The following is a description of a gene set: from publication Szanto A, Balint BL, Nagy ZS, Barta E, Dezso B, Pap A, Szeles L, Poliska S, Oros M, Evans RM, Barak Y, Schwabe J, Nagy L (PMID 21093321) Human Gene Set: GSE16385_IFNG_TNF_VS_UNSTIM_MACROPHAGE_ROSIGLITAZONE_TREATED_UP species: Homo sapiens Genes up-regulated in macrophages (12h): IFNG, TNF and rosiglitazone versus rosiglitazone. Human CD14 positive monocytes were purified from healthy volunteers’ blood and cultured in vitro for 4, 12, 24, 72 hours. While culturing, macrophages were activated alternatively with interleukin-4 (IL-4 100 ng/ml) or classically with interferon-gamma (IFNg 100 ng/ml)+tumor necrosis factor (TNF 50 ng/ml) or left without activation. Simultaneously, macrophages were also treated with vehicle (DMSO:ethanol) or 1mM synthetic PPARg agonist, Rosiglitazone. We used Affymetrix microarrays (U133Plus 2.0) to analyze activation and PPARg-induced gene expression changes., and this is the list of marker genes: SFT2D3, VTI1A, KEL, CARD11, EIF2AK2, EN1, LDLR, TBPL1, MAP7D1, LINC01093, ACAA1, SLC9A1, AIMP1, STAM, LRRN2, KRBA2, SAMD5, IL4I1, CGN, TEX46, BTN3A2, TMEM268, GPN2, PDXDC2P, RELA, GCH1, SUPT4H1, ZNRD2, XKR8, TRNAU1AP, LGALS3BP, PICART1, BCL7B, SDSL (NCBI Gene Id 113675), UBE2Z, ZNF496, KCNQ1OT1, IGHV1-69, MAX, HLA-J, USP11, CXXC1P1, MFN1, AKR1C4, UQCC6, RANGAP1 (NCBI Gene Id 6381), CBR1, ATG101, LINC01097, SEMA4D, TMEM87A, DCAF15, ZNF582-DT, RAB2B, INTS4P1, CCDC85A, SMAP1, CD70, DOCK8-AS1, ADCY7, DEXI, PSMA3, BST2, MYO19, NKAPL, MYL12A, CRY1, PPP4R3C, ADGRF1, COLEC11, RET, REPIN1 (replication initiator 1), IDNK, TBC1D21, CUL7, PCBP1, MFAP1, XPO1, C9orf85, EPHB2, MIR100HG, CD274, VAT1L, PAFAH1B2 (platelet activating factor acetylhydrolase 1b catalytic subunit 2), OR2M4, SLC31A2, ZBTB32, CRTC2, CENPF, IL6ST, IL10RA, PLPP6, DPM2, CC2D1A, ABTB2, INTS12, ATG4D, NPHS1, KIF26B, CFAP206, PARP12, ARHGEF11, SRP19, DAZAP1, PACSIN3, NOXO1, CRYBB2P1, NFKBID, FNBP4, TNS3 (tensin 3), SPTLC2, STIM2, NDE1, NR2C2AP, COX20, ARHGEF18, FAM149A, MED10, MRM3, CDT1, SLC35A4, ADRM1, ISG20, NIPSNAP3B, MRPS18C, LINC01220, IRAG1, TXLNA, ODAD4, RAB8A, TRIM33, PARP10, SLCO5A1, NLRP7 (NCBI Gene Id 50956), FOXL1, LSMEM1, NFX1, HECW1, BLZF1, PHF12, TRPC1, PPL, ENSG00000255537, ZNF350, MAN1B1-DT, MAGEB3, PATL1, HLA-C, CLCF1, ZNF296, NUDC, EPC2, LINC02372, NEAT1, ZFAND2A (NCBI Gene Id 90637), UBE2B, FANCL, PSMD12, CCRL2, B3GNT8, RPA2, REV1, MIR34BHG, KRT77, SPECC1L, OXLD1, CCDC28B, SAMSN1, LINC00607, SAMD9, ILF3-DT, CDC6, SMCR8, SLC34A3, DEPDC1, CISD2, FAAH, SSX5, MDM2, PRLR, SLAMF7, R3HCC1L, TXN (thioredoxin), FAM83A, CCDC140 (CCDC140 long non-coding RNA), BUD13, RASIP1, GBP1, RIPK1, LY6H